Given this list of marker genes Pex13, Pex7, Pex5l, Pex19 (peroxisomal biogenesis factor 19), Pex5, here is a description of the gene set: studied in species Mus musculus Mouse Gene Set: GOMF_PEROXISOME_TARGETING_SEQUENCE_BINDING Binding to a peroxisomal targeting sequence, a sequence of amino acids within a protein that acts as a signal for the localization of a protein into the peroxisome.